Given this list of marker genes TBX5 (T-box transcription factor 5), PLD1, FBN1, PCGF2, FLNA, GALE, COL5A1, FGFR1, CHST14, KRAS, COL1A1, COL5A2 (collagen type V alpha 2 chain), NDUFB11, HCCS, COX7B, here is a description of the gene set: One or more of the leaflets (cusps) of the tricuspid valve bulges back into the right atrium upon contraction of the right ventricle. species: Homo sapiens Human Gene Set: HP_TRICUSPID_VALVE_PROLAPSE Tricuspid valve prolapse